The following is a description of a gene set: Human Gene Set: HP_ABNORMALITY_OF_THE_DISTAL_PHALANX_OF_THE_THUMB Abnormality of the distal phalanx of the thumb species: Homo sapiens Any anomaly of the distal phalanx of thumb., and this is the list of marker genes: HOXD13, KIF7, GNAS, FLNA, ALG9 (ALG9 alpha-1,2-mannosyltransferase), KNSTRN, CANT1, UBAP2L, GLI1, MEGF8, CREBBP, EP300, SF3B4, BPNT2, ERI1, PAH, FGFR2, PTCH1, PIK3CD, KCNH1, IHH, FLNB, CILK1, GLI3, SLC26A2, CHSY1, GDF5, SALL4, BMPR1B, CWF19L1, PPP2R3C (NCBI Gene Id 55012), MAP3K7, DVL1, CNOT1